The following is a description of a gene set: studied in species Homo sapiens Programmed cell death that occurs in the developing retina. Human Gene Set: GOBP_RETINAL_CELL_PROGRAMMED_CELL_DEATH, and this is the list of marker genes: BCL2, TMEM215, BAX, CNTF, FGF2, FASLG